Given this list of marker genes PCDHA6, EMSY, ITGB8, E2F5, ESR1, KCNMA1, ARHGEF17, USP46, PHF6, RAB7A, UBE2Q2, EPHA2, ZBTB4, UBE2R2, UBR3, ATF6B, YWHAZ, SLC2A4, DAZAP2, RASSF2, TIPARP, FAM219B, SPOP, WDR45, SUGP1, MAPK9 (mitogen-activated protein kinase 9), MNT, RAB22A, NHSL3, IP6K1, PURB, WEE1, LHX6, PCDHA9, FLT1, MFAP3L, SPRTN, ZNF654, TXNIP, ARID4B, TRIM36, BLOC1S5, ZFP91, RAB11A, ULK1, ST8SIA2, ZKSCAN1, LEF1, DCUN1D1, PCDHA11, MTMR3 (myotubularin related protein 3), FAM13C, ANKRD13C, CCND1, MLLT6, MAP3K14, TENT5C, PARP8, KANSL1, TFAP4, PCDHAC2, PRRX1, RAB11FIP1, TNKS2, ZNF362, MBNL2, PCDHA2, PAN3, PCDHA3, RPS6KA5, TWF1, KMT2C, RAPGEFL1, TP53INP1, GATAD2B, PPP3R1, RALGDS, AGFG2, PAK5 (NCBI Gene Id 57144), MCCD1, CAMK2N1, PCDHA8, ECT2, NR2C2, KBTBD8 (kelch repeat and BTB domain containing 8), SSX2IP, RNF6, SS18L1, ANKRD54 (ankyrin repeat domain 54), PLEKHM1 (pleckstrin homology and RUN domain containing M1), PCDHAC1, KIF3B, GIGYF1, LATS2, NAPEPLD, ATXN1, NEK9, ARHGEF10, APP, PRDM8, CDK19, ZBTB6, SNX21, BAHD1, RRAGD, PLAGL2, COL23A1, SLC22A23, KLF13, CC2D1A, ZMYND11, ANO6, TRPV6, TP53INP2, GRHL2, UNKL, CNOT6, KAT2B, PPP6C, FEM1C, SEC62, KLHL3, AEBP2, KMT5B, RUNX1, ARID4A, ZDHHC9, ETV1 (NCBI Gene Id 221810), TLCD3A, REEP3, RBL1, TMUB2, NUFIP2, KPNA2, TOB2, TNFAIP1, RHOC, OPCML, RB1CC1, ZDHHC17, LYPD6, MCL1, MTERF4, ZNF385A, NEUROD1, VLDLR, ZBTB9, CAMTA1, DRD1, OSBPL8 (NCBI Gene Id 57601), C2CD2, CREB5, TET1, DPYSL5, SLC6A9, EDNRB, OXR1, RGMA, PCDHA7, ZNF512B, PHLPP2, SIK1, HAPSTR1, SENP1, MTUS1, YTHDF3, MYCN, SLITRK3, LCOR, UBE2B, CYP26B1, BCL6, PCDHA13, RPS6KA3, E2F7, NEO1, LEFTY1, RSRC2, HLF, TOX, OTUD4, KMT2A, FGD5, INTS6, TAL1, RPS6KA1, HNRNPH3, RAD23B, NEUROD6, CRK, MRPS25, CERS6, TBC1D8B, IGF2BP1, ZFPM2, TRIP11, YPEL2, MKNK2, SUV39H1, GNB5, TARDBP, FBXO11, FOXL2, BTG1, CRIM1, PAPOLA, ATAD2, PCDHA10, MAP3K11, DCAF6, PRRG1, ORMDL3, CDCA7, UBFD1, MEF2C, ASF1A, WDR37, MAML1, PCDHA1, INO80, UBE2W, DHX40, RGL1, UBE2J1, KLHL18, DNAJC27 (DnaJ heat shock protein family (Hsp40) member C27), SIPA1L3 (signal induced proliferation associated 1 like 3), PCDHA12, DNAJA2, ZNF800, BCL11A, SCRT2, USP42, ADAM9, RAB6A, NCOA7, ZFP36L2, GABPB2, FOXJ2, PRR16, DMTF1, LUC7L2, FAM117A, FRMD4A, INHBB, VEGFA, ALX4, TRPS1, MED12L, FNDC3A, RETREG3, BCL2L11, MARCHF8 (NCBI Gene Id 220972), ZNF436, PURA, MINK1, MPC1, MYRF, NR4A3, POLQ, JAZF1, MANEAL, PLEKHA3, MYT1L, JPT1, FNDC3B, CFL2, RSBN1, RABGAP1, CCND2, JRKL, RAB6C, TAOK2, EPAS1, DDHD1, CCNJ, PLXNA1, NFYA, ZNFX1, LMO3, KLF12, OLFM3, IQSEC2, HDAC4, RBBP7 (NCBI Gene Id 5931), TRAPPC14, SDC1, SYDE1, PCDHA5, VSX1, TLE4, ANK2, ZBTB11, NR4A2, ZNF2 (NCBI Gene Id 7549), NTN4, PRDM4, SAR1B, PCDHA4, SUCO, CELF2, CREBRF, YOD1 (NCBI Gene Id 55432), PBX3, ABCA1, PGBD5, CADM2, JOSD1, LHX8, NPAS3, BRMS1L, BAMBI, DUSP2, MECP2, TUSC2, NELFE, SYNC, ATP2B2, RIC8B, NFIB, ZBTB47, TRIR, HIC2, IRF2, ZBTB41, MKRN1, TSHZ3, ANAPC16, OSBPL5, PLAG1, SMAD2, MIER3 (NCBI Gene Id 166968), ARHGEF18 (Rho/Rac guanine nucleotide exchange factor 18), ZFYVE26, CLIP4, PFN2, AK2, ASF1B, PHF2, RABEP1, MMP24, DERL2, CRTC2, here is a description of the gene set: Genes having at least one occurence of the motif AGCACTT in their 3' untranslated region. The motif represents putative target (that is, seed match) of human mature miRNAs hsa-miR-93, hsa-miR-302a, hsa-miR-302b, hsa-miR-302c, hsa-miR-302d, hsa-miR-372, hsa-miR-373, hsa-miR-520e, hsa-miR-520a, hsa-miR-526b*, hsa-miR-520b, hsa-miR-520c and hsa-miR-520d (v7.1 miRBase). studied in species Homo sapiens Human Gene Set: AGCACTT_MIR93_MIR302A_MIR302B_MIR302C_MIR302D_MIR372_MIR373_MIR520E_MIR520A_MIR526B_MIR520B_MIR520C_MIR520D